The following is a description of a gene set: Human Gene Set: GOBP_HYALURONAN_METABOLIC_PROCESS The chemical reactions and pathways involving hyaluronan, the naturally occurring anionic form of hyaluronic acid. Hyaluronan is a type of non-sulfated glycosaminoglycan composed of the repeating disaccharide unit beta(1,4)-D-glucuronic acid-beta(1,3)-N-acetyl-D-glucosamine. studied in species Homo sapiens, and this is the list of marker genes: TNFAIP6, HYAL3, HYAL4, PDGFB, ITIH5, AP2A1, HEXB, TGFB1, ABCC5, ITIH1, SMPD3, HEXA, CLTC, CD44, ITIH6, IL1B, LYVE1, GUSB, HAS2 (hyaluronan synthase 2), ITIH4, HYAL1, CEMIP, HAS1, EGF, ITIH2, NFKB1, HMMR, FGF2, CEMIP2, ITIH3, HYAL2, HAS3, STAB2, SPAM1